The following is a description of a gene set: Reactome Pathway: RHOBTB3 ATPase cycle electronically inferred by orthology from the curated human pathway studied in species Mus musculus part of: Signaling by Rho GTPases, Miro GTPases and RHOBTB3 This event has been computationally inferred from an event that has been demonstrated in another species.<p>The inference is based on the homology mapping from PANTHER. Briefly, reactions for which all involved PhysicalEntities (in input, output and catalyst) have a mapped orthologue/paralogue (for complexes at least 75% of components must have a mapping) are inferred to the other species., and this is the list of marker genes: Plin3, Rab9b, Vhl, Ccne1, Htr7